Given this list of marker genes Srpx, Nr2f6, Tas2r123, Ptprq, Csrp3, Or4m1, Or9g19, Or10ab5, Grm8, Or10g3b, Kcnmb4, Grik2, Adora1, Or5v1b (NCBI Gene Id 545205), Vmn2r1, Prdm12, Gm7609, Trem2, Tnf, Scn9a, Or10aa1 (olfactory receptor family 10 subfamily AA member 1), Nr4a1, Atp2b2, Or2aj5, Or2ag2, Slc24a4, Pkd1l1 (NCBI Gene Id 171395), Kcnk2, Or2ag17, Or2ag20 (NCBI Gene Id 257902), Or2a56, Rcvrn, Or2v2, Or6k14, Or8g50, Tas2r131, Tmem87a, Or2bd2, Or8b8, Or5p58, Or2y1f, Or2y15, Or12j3, Guca1b, Nrg1, Tas2r105, Or2ab1, Tas2r144, Rpe65, Kcnq1, Or6n1, Pkd1l3, Or13ae2, Or2n1, Tlr4, Gnb1, Tac4, Or5p68, Or2ad1 (olfactory receptor family 2 subfamily AD member 1), Or10d5, Pigr, Or2ak7, Or2b11, Or10h28, Or2h1 (olfactory receptor family 2 subfamily H member 1), Piezo2, Ssc5d, Trpv1, Asic2, Rgr (retinal G protein coupled receptor), Or10al6, Or2n1e, Or2a57, Nod1 (NCBI Gene Id 232000), Kcnmb2, Or13c7c, Tas2r124 (NCBI Gene Id 387351), Gucy2d, Cxcl12, Cacnb4, Or5g25, Naip6, Or2a20, Col11a1, Grin2a, Or10a5, Cabp4, Or5t18, Or2r11, Or10ak9, Or6b9, Or2h1b, Or12e13, Ano3, Or10a3b, Prph2, Or6k4, Ntsr1, Strc, Or10aa3, Opn4, Lrit1, Or10a3n, Or4c3d, Extl3, Tas2r140, Or5t17 (olfactory receptor family 5 subfamily T member 17), Or2f1b, Or10d4, Or5an10, Scn10a, Or5p52 (NCBI Gene Id 258770), Or12d15, Or2ag15, Or10ak7, Tas2r126, Or5p56 (NCBI Gene Id 258928), Pkd2, Lbp, Or2ak5 (NCBI Gene Id 258494), Gja10, Crtam, Ccdc66, Mkks, Chrna9, Or5h17, Mmp24, Or6b1, Or10ag52, Or10a2, Or12j5, Ephb1, Asic3, Or10ag56, Opn5, Or2ag13, Tas2r119, Or2l13 (NCBI Gene Id 259071), Or10a48, Or2aj6, Or2z9, Or10g6, Tas1r3, Nox3 (NCBI Gene Id 224480), Or7a40, Gnat2 (NCBI Gene Id 99904), Or2y3 (NCBI Gene Id 258867), Or4b13, Ano1, Or10g9b, Tas2r113, Or4e2, Tas2r134, Tas2r109 (taste receptor, type 2, member 109), Pawr (PRKC, apoptosis, WT1, regulator), Or10j27, Or2d3c, Adgrv1, Chrna5, Or2b4, Or5ar1 (olfactory receptor family 5 subfamily AR member 1), Or2d4 (NCBI Gene Id 258594), Tas2r129, Or2m12, Or2y12, Sox2, Or13c25, Aipl1, Ly96, Or12d2, Or10g7, Rbp4, Or8a1, Or2w6, Or10al4, Tulp1, Or2ag19, Or1j21, Or2b7 (NCBI Gene Id 404335), Pkd2l1, Or2ah1, Or2av9, Or2n1d, Or6k2, Or10p1, Or2b2, Pde6d, Or2c1, Irx6, Kcnk3, Tas2r106 (NCBI Gene Id 387341), Or2f2, Tas2r121, Or10w1 (NCBI Gene Id 258098), Or12d14-ps1, Tmc1, Or5an1c, Or2j3, Or2t47, Tas2r110, Wdr47, Bace1, Or2z8, Pglyrp1, Or5p57, Tlr2, Atp8a2, Or10ak14, Or11m3, Otop1, Or12e8, Or1m1 (NCBI Gene Id 258599), Tlr1, Igf1, Tgfb3, Or2q1, Pkd1l2, Or10ad1b, Or2n1b, Or2w2, Or10d4b, Or10ak16, Or5an9, Or2b28, Or5p4, Tas2r108, Or10g1 (NCBI Gene Id 258423), Or10ag54, Or13f5, Or2y1c, Plcb2, Or10g9, Or2a52, Or5ap2, Or2w25, Rrh, Or8g18, Or10s1, Or13p10, Or1j1, Or10d3, Pglyrp4, Tas2r107, Or5p51, Or5g29, Or2n1c, Rtp2, Or13c7d, Or5p76, Lpo, Or10a3, Or10al2, Gngt1, Rtp4, Or10d4c, Or12e1, Arrb1, Tcap (NCBI Gene Id 21393), Tas2r136, Gpr88, Or2w1, Or2a7, Or4e5, Or2h2c, Clec4n, Or5j3, Or2d3b, Cngb1 (NCBI Gene Id 333329), Or10ag57, Ntrk1, Car6 (NCBI Gene Id 12353), Or2ak6, Or6a2, Or2d2, Or5an1b, Scn11a, Or10ah1-ps1, Or2a51, Pjvk, Gucy2f, Fyn, Or13n4, Tspo, Or6b13, Cds2, Ffar4, Grin2d, Or2g7, Or10d1, Or13p5, Or13e8, Tas2r115, Tas2r120, Or5an11, Gm15433 (predicted pseudogene 15433), Or2ag12, Or10al5, Tas2r143, Azgp1, Or10ag53, Or2r3, Pnpla2, Scn1a, Tas2r122, Or7a42, Or13d1, Or10al3, Or10ag58, Rtp1, Or2w1b, Or2y17, Pcdh15 (NCBI Gene Id 623239), Or8g17, Tas2r125, Or5d20-ps1, Or10p22, Or2y1g, Or10h5, Tmc2, Or2t46, Or2aa1, Cav3, Or5p6, Tas2r138, Or10k2, Or6n2, Comt, Or12k5, Atf2, Scarb1, Best1, Or2i1, Cep250, Or5h19, Or5p67, Tas2r103, Pdzd7, Or2t35, Or10ac1, Clec7a, Il18, Or2w3b, Chrna10, Or12e10, Opn1mw, Or2a54, Or2g1, Or5k16, Or13j1, Jup, Sema5a, Grm6, Or2ak4, Serpine2, Or51e2, Or2t1, Rgs9bp, Reg3g, Pip, Kit, Or2r2, Or2d2b, Or12d13, Or10z1, Or2t26, Or2y1e, Or2ag1, Ngfr, Kcnk4, Or2o1, Tlr6, Lxn (latexin), Or9s13, Or8b3, Or10j2, Cacna1f (calcium channel, voltage-dependent, alpha 1F subunit), Or8c8, Sema5b, Or2a25, Pkd1, Pglyrp2, Or10g3, Rest, Or10a4, Or6y1 (NCBI Gene Id 631073), Arrb2, Or5h18, Or10j3b, Tac1, Cxcr4, Or10ak13, Parg, Or5p62, Or2h15, Or5p53, Kcna1, Or2t43, Or12d16-ps1, Pcare, Whrn, Or5p79, Stim1, Or3a10, Or10h1b, Syt1, Ttn, Or2t44, Or5p73 (olfactory receptor family 5 subfamily P member 73), Or2g25, Fap, Cadm1, Itgav, Tas2r130, Naip2, Or5p69, Or4e1, Or12k8, Or2y6, Or2ag2b, Gm7582, Or13c7, Cacnb3, Itga2, Rho, Or5k17, Or8u3-ps, Or13g1, Pak1, Piezo1 (piezo-type mechanosensitive ion channel component 1), Kcnmb3, Or1r1, Or2f1, Or2m13, Or10u4, Tas2r117, Pde6c, Dach1, Or13p8, Or5p54, Or5t9, Ppef1, Or10ag60, Or2y11, Or2l5, Htr7, Or2y16, Tas2r135, Or5p59, Or10h1, Or5p70, Gpr52, Or10a3m, Cd209b, Or2y8, Pde6b, Or8u9, Or6p1, Or10n1, Nod2, Myc, Or5p72, Or2p2, Or2ag16, Gnat3, Or1e16, Or10ad1, Or10ak8, Or2a5, Or2y13, Or5p55, Vmn2r26, Or5p64, Or12j2, Or12e14, Or10g1b, Guca1a, Fech, Or5p81, Smo, Or11i1, Or2w4, Or12d17, Or5v1, Phf24, Or10j7, Calm3, Or2k2, Or10u3 (NCBI Gene Id 258266), Or10j3, Casp4, Drgx, Eng, Or10a49, Htr2a, Or5t7, Or5b21 (olfactory receptor family 5 subfamily B member 21), Crb1, Reep6, Or2ag1b, Nlrp3, Or13c3, Or2t6, Or5p60, Or2z2, Or2t49, Tas2r102, Or2y1d, Or12j4, Pkdrej, Or5g9, Ttr, Tas2r118, Or5an6, Or2v1, Or7e178, Or10ak11, Or2y14, Or2t29 (olfactory receptor family 2 subfamily T member 29), Or5an1, Grk1, Tas2r139, Or10d5j, Or2t45, Or10d1b (olfactory receptor family 10 subfamily D member 1B), Tas2r114, Or2d36, Naip1, Tmem120a, Trpa1, Calca (calcitonin/calcitonin-related polypeptide, alpha), Kcnmb1, Or2d3, Or7r1, Or12d12 (olfactory receptor family 12 subfamily D member 12), Or13c7b, Or10d1c, Or10am5, Calm1, Or10al7, Or2l13b, Or5m5, Opn1sw, Tas2r104, Pkd2l2, Or2j6, Or2t48, Or5p50, Sod2, Lhfpl5, Or10j5, Casr, Rtp3, Or7d11, Or2w3, Or10ag59, Or6aa1, Tas2r116, Tas2r137, Or2aj4, Or2y10, Gnat1, Or2b6, Opn3, Or6e1, Ryr2, P2rx2, Or5p80, Or10ak12 (NCBI Gene Id 435804), Nlrc4, Or13p4, Or10c1, Pglyrp3, Or2y1b, Cacna2d4, Or2y1, Pcp2, Or6z7, Or5p66, Or5g26, Or56b34, Tas1r2 (taste receptor, type 1, member 2), Or2ag18, Or2b2b, Foxf1, Grin2b, Calm2, Hpn, Cdhr2, Or13a1, Or2a14, Slc12a2, Or12e9, Or6ae1, Or13p3, Or12e7, Rom1, Scrn3, Or5p1 (NCBI Gene Id 258731), Or2a12, Tlr9, Or10ag2, Naip5, Or2h2, Or6k6, Disc1, Or10ab4, Ppef2, here is a description of the gene set: The series of events in which a stimulus is received by a cell or organism and converted into a molecular signal. Mouse Gene Set: GOBP_DETECTION_OF_STIMULUS studied in species Mus musculus